Given this list of marker genes SLC35D1, NUFIP2, TFAP4, STX12, EMX2, BNC1, CEP164, PIKFYVE, TRIP10, KDM2A, RPS6KA5, PTHLH, SSH1, PHC3, TCIM, GRIN2A, MYRF, IGF1, UXS1 (NCBI Gene Id 80146), SRGAP1, ZFYVE9, EFR3A, CNOT6, GALNT13 (NCBI Gene Id 114805), HIVEP2, TNKS1BP1, RAB8A, TLX1 (T cell leukemia homeobox 1), TEX2, SORL1 (sortilin related receptor 1), CEP97, TANC2, SEMA7A, IFNAR2, E2F1, CRY2, ZHX2, SFMBT1, OTUD7B, SLC24A2, SON, USP6, SMYD2, PPP1R9A, NFIA, CAMSAP2, LMX1A, NCKAP5, DNAL1, ZBTB18, CDC37L1, CLCN3, HOXA3, BLCAP, PHTF2, ZNF217, SNRK, ANKIB1, ZFAND4, PGM2L1, SATB2, SYDE2, ZBTB5, SNX5 (NCBI Gene Id 27131), R3HDM1, PLIN2, FASTK, BMPR2, ACVR1, SMOC1, HPS5, SUV39H1, RXFP1, NELL2, CCDC88A, EFNA5, HSD17B11, FRMD6, E2F7, BCO1, HS3ST5, PDZD11, MOSMO, CHRM2, AAK1, MAP7, SCN2B, VASH2, IKZF2, BTBD7, EIF4E2, GAB1, EMSY, CPEB1, TAOK1, CEP120, ROCK2, PRKAA1, ESR1, ACSL4, SOS1, BTBD10, GABRR1, FCHO2, PDE3B, TAPT1, CAPRIN2, SNIP1, USP32, TSG101, LATS2, PSD, PCDHB4, MAP1B, TFCP2L1, HBP1, TMOD2, ADIPOR2, KMT2A, CPEB3, TSEN34, CDADC1, ACTL6A, KIF13A, TOX3, KCNJ10, SCUBE3, KBTBD2, BICD2, SLAIN2, APCDD1, MAN1C1, FIBIN, CIT, ILF3, MDM4, TMEM64, RPRD2, AGO1, VLDLR, LARP4, USP31, ARX, ZBTB4, MAPRE1, PIGA, ITCH, MYT1L, HSPA8, SETD5, ERCC4, LRP4, CHD9, IQCH, KRT23, DYNC1LI2 (dynein cytoplasmic 1 light intermediate chain 2), MAP3K8, ASXL2, CREB1, MBNL3, GPR158, FBXO48, DCAF8, LCLAT1, RAD51B, CNOT7, PRR15, HABP4, GOLGA1, GRM5, RAPGEF4, PPP1R3B, DPYSL2, FAM199X, RASGEF1A, SLC17A6, ATP12A, ZNF711, HEG1, SKIDA1, NAA50, TMEM170B, GJA1, IRF2, CFL2, HIF1AN, TP63, PDCD1LG2, MASTL, WDR33 (WD repeat domain 33), HAS2, TAFA1, JAK1, RTN1, PIGS, JAKMIP1, ERBIN, NMUR2, CHD5, HFM1, LDLR, ARHGEF11, RAB5C (RAB5C, member RAS oncogene family), CENPO, SPOPL, NACC2, ITGB4, PRDM8, STK17B (serine/threonine kinase 17b), ATG16L1, FANCM, ARHGAP1, ENPP5, HAS3, SOBP, GPR137C, RORB, MOB1B, CUL3, FSTL5, ABRAXAS2, NEUROG1, FBXW11, CPA3, PARP1, FZD6, ANKRD13C, ATXN1L, ZNFX1, KBTBD8 (NCBI Gene Id 84541), NR2C2, BECN1, CREB5, EZH1, ARAP2, CR2, CDK2, ATXN7L1, TNFRSF21, PIK3AP1, NRP2, SOCS6, CBX6, MAB21L1, KIF23, BAG5, ELK3, SFRP4, MYOCD, IRF2BP2, UBE3A, TESK2, STXBP5L, DLG5, BRWD1, RNF216, LPGAT1, HYCC2, EIF4G2, USP28, MTMR4, CTSK, FOXF2, ZNF704, FYCO1, ITPR1, NRSN1, MAPK1, PPP1R15B, PROX1, DENND10, NPAS2, SMAD5, INSYN2B, FBXL5, MIER3, RUFY2, ARID4B, PXK, NHLH2, SPTY2D1, MIGA2, KLHL20, HNRNPUL1, SLAIN1, FAM117B, FAM169A, RNF128, CREBRF, LRIG1, LIMA1, MYLK, FAM78A, RASD1, MYBL1, BTG3, SGMS1, NALF1, ZFP91 (NCBI Gene Id 80829), ARHGAP12, NIN, CNOT4, ANKRD29, DNAJB9, EREG, HIF1A, WDFY3 (NCBI Gene Id 23001), RUBCN, HECA, TIPARP, NAA30, KCND2, TRERF1, USP3, IL1RAP, MBNL1, SH3PXD2A, MEX3D, ANKFY1, PLCB1, PHF14, REPS2, PKD2, ARHGAP24, ZNRF3, HMGB3, DCBLD2, ARID4A, TMEM168, ZNF236, L3MBTL3, FJX1, ZNF367, ATP6V1C1, ARHGAP29, SALL3, KREMEN1, MAPK4, POLQ, YTHDF2, CASD1 (CAS1 domain containing 1), KLHL28, SLC40A1, EPHA4, CMPK1, ZNF250, MAP3K12, ZNF652, ABHD3, IER3IP1, RAP2C, UHRF2, KCNA1, AFG1L, TMEM50B, TOPORS, MRRF, GUCY1A1, PAFAH1B1, RACGAP1, PPP6R2, COA1 (NCBI Gene Id 55744), STXBP5, SACS, ENTPD4, ZFHX4, DIP2A, NFIB, E2F2, DNAJC16, NAGK, PITPNA, WDR20, RASL11B, TGFBR2, NABP1, LAPTM4A, SAMD8, PHKA1, NKIRAS1, FMR1, KCNK10, ATP2C1, BTF3L4, ITPRIPL2, FBXL17, ABL2, MAP3K2, CYP4V2, LIMK1, FOXJ3, ZDHHC14, KMT2B, STX6, GDA, CRISPLD1, FILIP1L, PTPN4, INTS6, PRDM16, SAMTOR, GRB10, PXYLP1 (2-phosphoxylose phosphatase 1), MAP3K9, here is a description of the gene set: from publication Chen Y, Wang X (PMID 31504780) studied in species Homo sapiens Human Gene Set: MIR519C_3P Genes predicted to be targets of miRBase v22 microRNA hsa-miR-519c-3p in miRDB v6.0 with MirTarget v4 prediction scores > 80 (high confidence targets).